The following is a description of a gene set: studied in species Mus musculus Mouse Gene Set: GOBP_PLATELET_ACTIVATION A series of progressive, overlapping events triggered by exposure of the platelets to subendothelial tissue. These events include shape change, adhesiveness, aggregation, and release reactions. When carried through to completion, these events lead to the formation of a stable hemostatic plug., and this is the list of marker genes: Gata1, Rasa3, F2rl3 (F2R like thrombin or trypsin receptor 3), Sh2b3, Cela2a, Plek, Axl, Gla, Tspan9 (tetraspanin 9), Srf, Fundc2, P2ry1, Mfsd2b, Tyro3, Bloc1s4, F11r, Il6ra, C1qtnf1, Jak2, Svep1, Pdia3, Pla2g4a, Syk, Ubash3a, Ptpn6, Pear1, Fcer1g, Apoe, Adra2b, Tspan32, Mmrn1, Ptprj, Pik3cb, Fermt3, Adra2a, Gp5, Fgg, Rap2b (RAP2B, member of RAS oncogene family), Ubash3b, Slc6a4, Pdgfra, Prkg1, Vwf, Pdia6, Gp1bb, C1galt1c1, Emilin2, Emilin1, Tubb1, Pdia2, Mertk, Selp, Tec, Pdgfa, Stxbp3, Lyn, F2r, Entpd2, Il6, Alox12, Gnas, Prkcq, F2, Ctsg, Prkca, Tmx1, Pf4, Hrg (NCBI Gene Id 94175), Evl, Gp9, Pip5k1c, Fzd6, Htr2a, Pdgfb, Adra2c, Cfh, Comp, Fga (NCBI Gene Id 99578), Vps33b, Fgb, Adamts18, P2ry12, Serpine2, Gna13, Itpr3, Itgb3, Ppia, Cd9, Treml1, Stxbp1, Bloc1s3, Ceacam1, Pdia4, Wnt3a, Gp6, Tlr4, Entpd1, Gp1ba, Cd40lg, Gnaq, P2rx1, Slc7a11, Flna (filamin, alpha), Prkcd, Pdpn